Given this list of marker genes Shh, Wnt3a, Gsk3b, Hprt1, Pax2, Hif1a, Foxa2, Rac1, Dmrta2, Wnt3, Otp, Wnt9b, Nr4a2, Lmx1a, Ctnnb1, Vegfd, En2, Cdnf, Ferd3l (NCBI Gene Id 114712), Phox2b, Foxa1, Pax5, Htr7 (NCBI Gene Id 15566), Fgf8, Cxcl12 (NCBI Gene Id 20315), Pitx3, Csnk1d, Id2, Rspo2, Fmc1, Ryk, Dkk1, Vegfa, Dvl3, Neurog2, Otx2, Smo, Wnt2, Wnt5a (wingless-type MMTV integration site family, member 5A), En1 (engrailed 1), Tiam1, Lrp6 (low density lipoprotein receptor-related protein 6), Lmx1b, Sfrp1, Tshr, Wnt1, Sfrp2, here is a description of the gene set: The process in which a neuroblast acquires the specialized structural and functional features of a dopaminergic neuron, a neuron that secretes dopamine. species: Mus musculus Mouse Gene Set: GOBP_DOPAMINERGIC_NEURON_DIFFERENTIATION